Given this list of marker genes Nipbl, Wbp2, Macroh2a1, H1f5, Ctcfl, Ruvbl2, Macroh2a2, Mir208b, Lrwd1, here is a description of the gene set: studied in species Mus musculus Mouse Gene Set: GOBP_ESTABLISHMENT_OF_PROTEIN_LOCALIZATION_TO_CHROMATIN The directed movement of a protein to a part of a chromosome that is organized into chromatin.